The following is a description of a gene set: Genes predicted to be targets of miRBase v22 microRNA mmu_miR_1897_3p in miRDB v6.0 with MirTarget v4 prediction scores > 80 (high confidence targets). Mouse Gene Set: MIR_1897_3P species: Mus musculus from publication Chen Y, Wang X (PMID 31504780), and this is the list of marker genes: Bdh1, Erg, Scai, Golph3 (golgi phosphoprotein 3), Fli1, Slfn9, Tbx3, Ergic1